Given this list of marker genes Psmd12, Trp53, Psma6, Psmc6, Psma7, Psmb6, Chek2, Ubb, Psmc5, Psma2, Psmc2, Psma4, Psmc4, Psmb4, Psmb5, Psma3, Psmd7, Psmd6, Psmd1, Psma5, Psma1, Psmc3, Psmc1, Psmb7, Rps27a, Phf20, Psmd13, here is a description of the gene set: electronically inferred by orthology from the curated human pathway This event has been computationally inferred from an event that has been demonstrated in another species.<p>The inference is based on the homology mapping from PANTHER. Briefly, reactions for which all involved PhysicalEntities (in input, output and catalyst) have a mapped orthologue/paralogue (for complexes at least 75% of components must have a mapping) are inferred to the other species. Reactome Pathway: Stabilization of p53 studied in species Mus musculus part of: p53-Dependent G1 DNA Damage Response